The following is a description of a gene set: A bilateral tonic-clonic seizure with generalized onset is a type of bilateral tonic-clonic seizure characterized by generalized onset; these seizures rapidly engage networks in both hemispheres at the start of the seizure. Bilateral tonic-clonic seizure with generalized onset studied in species Homo sapiens Human Gene Set: HP_BILATERAL_TONIC_CLONIC_SEIZURE_WITH_GENERALIZED_ONSET, and this is the list of marker genes: TBC1D24, SLC6A1, FBXL4, PCYT2, CTCF, TSEN15 (tRNA splicing endonuclease subunit 15), GABRA5, IREB2, JRK, AP2M1, SCN9A, KCNMA1, TSEN54, KCNQ3, SLC9A6, CILK1, CPLX1, CLCN2, SLC32A1, COQ5, GRIN2A, SEPSECS, CNTNAP2, DDX59, POGZ, SLC2A1, SCN1B, COX8A, PCDH19, GBA1, TSEN34, ADGRG1, NEXMIF, PURA, GABRG2, GABRA1, EXOC8, PTEN, SCN2A, SCN1A, GABRD, CRELD1, TMX2, ASAH1, CHD2, CACNB4, UBE3A, TSEN2, EFHC1, SYNGAP1, SLC4A10, NARS1 (asparaginyl-tRNA synthetase 1), VPS53, GAD1, MAST3